Given this list of marker genes Synj2bp, Yes1, Igf2bp2, Dennd1b (NCBI Gene Id 77060), Adamts7, AI593442, Zfp704, Scd1, Gng2, Sipa1l1, Cd164, Rock1, Figla, Zfp474, Pcnp, Camk4, Chdh, Aadacl2fm1, Phf6, Dcdc2c, Selenot, Rgs7, Fam169a, Mmgt1, Arfip1, Khsrp, Fcrl5, Tmed7, Chrna10, Fbxl2, Pof1b, Rfesd (NCBI Gene Id 218341), Mapk1, Dera, Or12j5 (olfactory receptor family 12 subfamily J member 5), Zfand5, Adss1, Ccnk, Farp1, Gtf2a1, Lin9, Gpbp1, St18, Nhsl2, Gbp9, Efnb1, Zbtb2, Gcnt1, Asah2, Doc2b, Ankrd69, Trpc7 (transient receptor potential cation channel, subfamily C, member 7), Zfp292, Sp3, Zfp81, Wdr44 (WD repeat domain 44), Pdgfrl, Celf4, Lins1, Styx, Prpf4b, Fam241a, 0610030E20Rik, Jrkl, Tmem132a, Scn3b, Rbm7, St6galnac2, Nox4, Itgb6, Fign, Lats2, Car2, Nr3c2, Smoc2, Iho1, Pde1a, Slc23a3, Grik2, Qpct, Zkscan2, Srrm2, D630003M21Rik (NCBI Gene Id 228846), Dock11, Dcun1d1, Wapl, Pclo, Apc, Irs4, Mnat1, Gls, Dcun1d4, Matr3, Smarcad1, Insyn2a (NCBI Gene Id 627214), Erlec1, Mtx3, Rnf32, Rbbp8, Fga, Gmnc, 1700017N19Rik, Zfp36l2, Opa1, Tnik, F7, Bri3, Magel2, Ccser2, Ercc8, Slc33a1, Tfam, Scn8a, Ccdc88a, Tbca, Rhoq (ras homolog family member Q), Dpy19l1, Ccne2, Ehd3, Pygo1, Zfp383, Fndc4, Homer2, Gdpd1, Rnaseh2c, Pmp22, Hsph1, Zfp326, Ints2, Nxt2, Elavl1, Pfkfb4, Zfand1, Rps6kb1, Naaladl2, Erbb4, Fstl5, Nps, Ifih1, Upf2, Foxo4, Neurod2, Prickle2, Gda, Tmem161b, Kcna6, Or52z1, Mmrn1, Mak16, Lmx1a, Efr3a, Npy2r, Camk2d, Aldh6a1, Gabpa, Txn1, Ptpre, Gabpb1, Arid2, Krtap26-1, Arcn1, Spink13, Rad23b, Negr1, Tmem50b, Lrp6 (low density lipoprotein receptor-related protein 6), Ift27, Ubxn7, C6, Sos1, Ankzf1, Cdk17, Cfap299, Rnase4, Hdhd2, Fgf23, Uba6, Dph3, here is a description of the gene set: Genes predicted to be targets of miRBase v22 microRNA mmu_miR_3071_5p in miRDB v6.0 with MirTarget v4 prediction scores > 80 (high confidence targets). from publication Chen Y, Wang X (PMID 31504780) studied in species Mus musculus Mouse Gene Set: MIR_3071_5P